The following is a description of a gene set: A simultaneous engagement of different pathogen recognition receptors provides a tailor made adaptive immunity for an efficient defence against distinct pathogens. For example, cross talk of TLR and c-type lectin signalling effectively shapes distinct gene expression patterns by integrating the signals at the level of NF-κB. Here, we extend this principle to a strong synergism between the Dectin-1 agonist, curdlan, and an inflammatory growth factor, GM-CSF. Both together act in synergy in inducing a strong inflammatory signature which converts immature DCs to potent effector DCs. A variety of cytokines (IL-1β, IL-6, TNF-α, IL-2 and IL-12p70), costimulatory molecules (CD80, CD86, CD40 and CD70), chemokines (CxCl1, CxCl2, CxCl3, CCl12, CCl17) as well as receptors and molecules involved in fugal recognition and immunity such as Mincle, Dectin-1, Dectin-2 and Pentraxin 3 are strongly up-regulated in DC treated simultaneously with curdlan and GM-CSF. The synergistic effect of both stimuli resulted in strong IKBα phosphorylation, in its rapid degradation and in enhanced nuclear translocation of all NF-κB subunits. We further identified MAPK ERK, as one possible integration site of both signals, since its phosphorylation was clearly augmented when curdlan was co-applied with GM-CSF. Our data demonstrate that the immunomodulatory activity of curdlan requires an additional signal provided by GM-CSF to successfully initiate a robust β-glucan specific cytokine and chemokine response. The integration of both signals clearly prime and tailor a more effective innate and adaptive response against invading microbes and fungi. Human Gene Set: GSE32986_CURDLAN_LOWDOSE_VS_CURDLAN_HIGHDOSE_STIM_DC_UP Genes up-regulated in bone marrow-derived dendritic cells treated with 1,3-beta-D-oligoglucan: low dose versus high dose. from publication Min L, Isa SA, Fam WN, Sze SK, Beretta O, Mortellaro A, Ruedl C (PMID 22250091) studied in species Homo sapiens, and this is the list of marker genes: ABHD12, TMEM170B, KIF13B, SRPK2, ERLIN1, PAOX, SAMD1, ATRAID, RASSF3, MOCOS, ARID1A, SESN1, UNC50, RNF44, MFSD11, MAF, CAMK2G, SLBP, CAMSAP2, CSK, PDE7B, RETREG1, MEF2C, CALHM2, KIF23, RCBTB2, CDCA2, ANGPTL4, IPCEF1, ZRANB3, ADAMTS10, NHERF1, KIAA0513, HEATR5A (HEAT repeat containing 5A), NCBP2AS2, FES, TMEM106B, RPS6KA1, CLEC7A, DHRS3, ACAP2, SLC46A3, MBTPS1, SNX9, PLA2G15, TMT1A, DIP2B, H2BC5, HPCAL1 (hippocalcin like 1), INPP5F, NIN, MAN2A2, DDIT3, TMCC2, ECH1, FAM217B, BCL2L11, R3HDM1, SURF1, CNPY4, FCGR2A, LYL1, PCMTD2, ACOT13, GOT1, TBXAS1, ESYT1, SSBP4, RTL5, GRN, TMEM126B, GPR146, MCM10 (minichromosome maintenance 10 replication initiation factor), MDP1, RELL1, FLI1, RELCH, TPST2, MCM7, STARD9, RGS2, MACIR, NEURL2, KAT8, ATG4C, SSH2, OSGEPL1 (O-sialoglycoprotein endopeptidase like 1), MKNK2, ST6GAL1, TFAP4, L1CAM, MARCHF6, MSRB1, ANKRD44, RBFA, POLR2E, ZFP36L2, RNASEL, BTBD1, KLHL6, GALNT9, ITGA6, ALOX15B, SLC18B1, SIPA1, GADD45A, ARHGAP9, MFSD12, IGIP, MESD, LGALS8 (NCBI Gene Id 3964), FBXO5, NHSL3, RAPH1, INPP5D, ITSN1, MCTP1, HMG20A, ZC3H6, ABCD2, PHACTR4, CIPC, NDUFS5, FOXO3, LUC7L3, GPR155, PPM1H, ITGB2, TCF12, CLDND2, CACFD1, HPS5, PPP1R12C, CNKSR3, RNASE4, LPXN, TMEM230, TMCO1, CHMP1B, ACOX3, TPCN1, PDP1, STARD8, PIKFYVE, CAST, CD28, PSPH, CNR2, TET1, DYNLT1, TLR4, ELMOD2, AATK, DAB2, STXBP5 (NCBI Gene Id 134957), TM6SF1, SGSH, DNMT1, ARHGAP25, NTAQ1, C19orf12 (chromosome 19 open reading frame 12), INTS6L, GPD1L, RGS14, TMEM65, MINDY2, BNIP3L, APC (NCBI Gene Id 324), MERTK, ETHE1, OTUD1, UBN1, SLC8A1, LONRF3, SVIL, FBH1, AFTPH, PURG, TMLHE, PGAP6, RAB11FIP5, CASP3, CXCR4, PDGFC, BMF, THRA, MRPL24, TNFAIP8L2, WDSUB1, ZNF708, VSIR, PACS2, GNS, RNF144B, IKBIP, COA6, ULK1, ZNF688, KIF5A, FAM110C